The following is a description of a gene set: species: Homo sapiens A collagen heterotrimer containing type VI alpha chains in alpha1(VI)alpha2(VI)alpha3(VI) trimers; type VI collagen triple helices associate to form beaded fibrils. Human Gene Set: GOCC_COLLAGEN_TYPE_VI_TRIMER, and this is the list of marker genes: COL6A6, COL6A5, COL6A2, COL6A3, COL6A1